The following is a description of a gene set: Human Gene Set: GOBP_REGULATION_OF_SPINDLE_CHECKPOINT Any process that modulates the rate, frequency, or extent of the spindle checkpoint, a cell cycle checkpoint that delays the metaphase/anaphase transition until the spindle is correctly assembled and oriented, and chromosomes are attached to the spindle. studied in species Homo sapiens, and this is the list of marker genes: CDCA8, PRAP1, MAD1L1, TPR, SKA1, MAD2L1, NDC80, USP44, INCENP, SKA3, MAD2L1BP, BIRC5, AURKB, KNL1, ZWINT, CDK5RAP2, ANAPC15, XRCC3, GEN1, DUSP1, DYNC1LI1, CCNB1, PRP4K, LCMT1